The following is a description of a gene set: Human Gene Set: FAN_EMBRYONIC_CTX_BIG_GROUPS_MICROGLIA from publication Fan X, Dong J, Zhong S, Wei Y, Wu Q, Yan L, Yong J, Sun L, Wang X, Zhao Y, Wang W, Yan J, Wang X, Qiao J, Tang F (PMID 29867213) studied in species Homo sapiens, and this is the list of marker genes: SLC7A8, SERPINF1, GLRX, SYK, LY86, LPCAT2, CD4, SALL1, C1QB (complement C1q B chain), TNFRSF1A, LGALS9, HMOX1, BCAP31, MFSD1, ITGB2, APBB1IP, CD164, TMT1A (thiol methyltransferase 1A), PRR13, HSPA5, IKZF1, H2AJ, HLA-C, NFKBIA, PDGFB, SIRPA, LPAR6, FCGR2A, TREM2, HSPA1B, GNG5, ANXA5, POLD4, B2M, IRAG2, PLD4, BHLHE41, DOCK8, FOSB, RNASE6, ABI3, CSF3R, STOM, TMIGD3, ENTPD1, MS4A7, TAGAP, CPVL, GPX1, SERPINA1 (NCBI Gene Id 5265), VSIR, FYB1, NEAT1, SAMSN1, DPP7, PSAP, IGSF6, CD14, BST2, GPR183, RGS10, OLFML3, MAN2B1, TGFBR2, BIN1, CTSH, LST1 (NCBI Gene Id 7940), RHOB, HLA-E, COLGALT1, BIN2, MROCKI, LYST, JUN, LAIR1, NFKBIZ, TAL1, SERPINB6, C3, FMNL3, SELPLG, IL6ST, FGD2, FCGR1A, ITGAX, NFE2L2, PPT1, VSIG4, LINC02256, MPEG1, CMTM6, PPP1R15A (protein phosphatase 1 regulatory subunit 15A), TLR10, APLP2, FPR1, NCKAP1L, HERPUD1, CYBB, GSN, ATP6V0E1, DUSP1, GMFG, OSTF1, ARPC3 (NCBI Gene Id 10094), LAT2, GGTA1, NPL, MGST2, ACY3, CRYBB1, EGR1, MERTK, DAGLB, CSF1R, RNASET2, LCP1, LILRB4, CD81, PDK4, CD68, ABCG2, IER3, LYN, VAMP8, TMEM119, DHRS9, P2RX4, SERF2, SKAP2, CXCL16, GAS6, ADAM28, RGS19, CIAO2A, WASF2, SYNGR2, AOAH, HSPA1A, RUBCNL, IGF1, GATM, HCST, CHCHD7, GLUL, C12orf75, LHFPL2 (LHFPL tetraspan subfamily member 2), FOLR2, SLC29A3, PLXDC2, ZFP36, CYBA, CREG1, NAIP, NCF4, GPSM3, SP100, GIMAP4, ZFHX3, UCP2, AIF1, PTGS1, VMP1, IL17RA, CH25H, LIPA, CTSB, PARVG, MEF2A, TYROBP, ELF1, CD86, DOCK4, CD36, TCIRG1, INPP5D, FCGR1CP, EPB41L2 (NCBI Gene Id 2037), ARRB2, PTPRE, MGAT4A, DAB2 (NCBI Gene Id 1601), JUNB, MNDA, STING1, MKNK1, IFI30, PLVAP (plasmalemma vesicle associated protein), HTRA1, LIMS1, DEGS1, RNF213, TAPBP, LINC02712, OAS1, MYO1F, DNASE2, IL10RA, SRGN, DDIT4, LGMN, IL6R, EGFL7, KCTD12, CAPZB, CAP1, ARHGDIB, TMEM35B, HVCN1, SFMBT2, NINJ1, GRN, ITM2B, C3AR1, P2RY13, BLNK, CD84, PTPN6, PPP1R18, RAB3IL1, CORO1A, STAB1, CPED1, MED12L, SLCO2B1, NAGA, RHBDF2, ATP8B4 (NCBI Gene Id 79895), APPL2, LY96, IPCEF1, CTSC, OTULINL (NCBI Gene Id 54491), CKS2 (NCBI Gene Id 1164), CCND1, PFN1, GAL3ST4, IRF8, CYTH4, P2RY12, TLR4, OLR1, ADAM9, C1QC, ZFP36L2, COTL1, LAMP2, EVI2A, H1-2, CD37, MILR1, XBP1 (X-box binding protein 1), GPR34, NAA20, GPN3, LPAR5 (lysophosphatidic acid receptor 5, NCBI Gene Id 57121), FOS, DNAJB1, PDPN, ADAP2, TMEM52B, ADRB2, MIS18BP1, NPC2, SCAMP2, CCR1, ITPR2, RGS1, CYFIP1, REEP4, LAPTM5, SIGLEC8, SIGLEC10, SCAF11, PLEK, TLR7 (NCBI Gene Id 51284), C2, CD83, BTG2, CASP1, GM2A, CMTM7, TNFRSF1B, SLC9A9, APOC1, B3GNT5, CD74, TMBIM4, ATP6V0B, DHRS3, TPP1, RGS2 (regulator of G protein signaling 2), ALOX5AP, HCLS1, IL13RA1, CTSL, OTUD1, SLC1A3, ITGAM, FCGRT, PLD3, ZFP36L1, VDAC1, IFNGR1, SAT1, CCL4, TLN1, LAP3, HAVCR2, CTSD, GLIPR1, CTSS, IER2, ST6GAL1, RB1, GNB4, HEXA, RNF130, RIN2 (Ras and Rab interactor 2), SOCS6, GYPC, GNG7, SUSD3, SERPINB9, ADORA3, IFI16, HHEX, RHOG, ASAH1, KLF2, SORL1, CNPY3, FCGR1BP, ARPC1B, CD300A, GADD45B, S100A11, PLA2G15, EVI2B, DOCK2, SERP1, HLA-B (NCBI Gene Id 730410), CALR, PIH1D1, MRC1, SLC7A7 (solute carrier family 7 member 7), HCK, LINC00996, SPP1, TFEC, PTPRC, C1QA, TBXAS1, ARHGAP4, CEBPD, CX3CR1, HPGDS, PTAFR, FCER1G, RCSD1, A2M, CCL3, AP1B1, HSPB1, APOE, CD53, GAA, FCGR3A, MAF, XAF1, PYCARD, LTC4S